The following is a description of a gene set: Genes predicted to be targets of miRBase v22 microRNA hsa-miR-618 in miRDB v6.0 with MirTarget v4 prediction scores > 80 (high confidence targets). species: Homo sapiens Human Gene Set: MIR618 from publication Chen Y, Wang X (PMID 31504780), and this is the list of marker genes: PRAME, DUSP10 (dual specificity phosphatase 10), CBX5, CDC7, PLEKHB2, ZNF302, FXR1 (FMR1 autosomal homolog 1), SEPTIN6, KLF10, ITPRID2, C17orf75, SLC4A4, DMXL2, TENM1, JAZF1, MBNL3, IQUB, SNX14, USP38, ADGRF5, DCAF5, UBE2A, H2AJ, YTHDC1, SALL1, PAX3, ZKSCAN8, KDM4C, HHIP, CHEK1, NCOR1, SLC35F5, AFDN, GBP5, ITPRIP, PLSCR4, CAVIN2, ZNF652, FEM1C, SLC39A10, PALM2AKAP2 (NCBI Gene Id 5561), KLF3, TMEM230, CBX8, OGFRL1, ELOC, ZNF275, VPS41, TGFB2, ATP11B, ITCH, ACOX1, XK, RAB1A (NCBI Gene Id 5861), ZFAND1, ROCK2, METTL6, GIPC2, KCNC2, SIPA1L1, UFD1, FGFRL1, PLP1, EIF4A2, CBLL1, NUP214, DENND5A, KRT12, RASA2, LSM1, PCYT1A, C5orf24, ZNF532, ABLIM2 (actin binding LIM protein family member 2)